The following is a description of a gene set: from publication Chen Y, Wang X (PMID 31504780) studied in species Mus musculus Mouse Gene Set: MIR_6342 Genes predicted to be targets of miRBase v22 microRNA mmu_miR_6342 in miRDB v6.0 with MirTarget v4 prediction scores > 80 (high confidence targets)., and this is the list of marker genes: Chek1, Ythdc1, Colq, Fam151b, Helz, Erlin2, Kpna1, Atf6, Ccnjl, Slit2, Btg2, Rnf144b, G0s2, Cdk5r1, Epha7, Lrig1 (NCBI Gene Id 232256), Ist1, Tbpl1, Dixdc1, Tmem135, Slc4a4, Rab11fip1, Itpr1, Adrb2, Cert1, Mlycd, Casr, Cacul1, Vegfa, Pnpla6, Gbp2b, Syde2, Stradb, Fmn2, Lats1, Wipi2, N4bp1 (NCBI Gene Id 97462), Nuak2, Satb2, Rfx3, Bcl2, Anks1, Adissp, Crebl2, Ywhah, Slc4a7, Plpp1 (phospholipid phosphatase 1), Slc7a2, Sema3a, Dnajc16, Tmem74b, Kctd8, Tgfbr3, Sptbn2, Atxn2, Plcxd2, Arhgap12, Srpra, Cpsf7, Pnoc, Med26, Pip4p2, Ppp6c, Prmt6, Dcp1a, Garem1, Man2a2, Dclk1, Ptpn3, Plxna2, Ubfd1, Grm7, Tmcc1, Kif5c, Bcl2l2, Zfp367, Ccdc85b, Usp42, Kcnj2, Cfap45, Spag7, Zcchc3, Rreb1, Cc2d1b, Tacc1, Mmd, Ncs1, Arih1, Kbtbd2, Myt1l, Peli3, Dll1, Igf2r, Plxna4, Nrn1, Nos1, Abtb2, Sec61a1, Omg, Suco, Ret, Desi1, Smurf1, Selenoi, Zmym2, Krtap11-1, Sall1, Ccnd2, Ippk, Dennd10, Rnf10, Septin2 (septin 2), Eif3a, Cobll1, Capns1, Nectin1, Atp1b4, Atxn7l3, Eya1, Cdk12, Gm5460, Akap7, Ube4b, Nup210, Tuba4a, Mgat4a, Pla2g15, Amotl1, Lhx3, Zfp449, Trabd2b, Hmga1, Ddx3x, Sel1l3, Rasgef1b, Atp2b2, Wbp11, Zswim3, Kif21a, Idh3a, Il10ra, Nav1, Pdxk, Rfc1, Son, Usp25, Cd2ap (CD2-associated protein), Plekhm3, Ahcyl2, Ago4, Penk (preproenkephalin), Bicd1, Slc13a3, Chpt1, Rnf217, Ccdc6, Rbm6, Gpatch8, Capn6, Chd2, Trank1, Pth (NCBI Gene Id 57388), Cdc25a, Prrc2c, Slc25a22, Arfgap2, Arhgdia, Spred1, Usp12, Acvr2a, Plxnc1, Cpeb3, Ankrd13b, Hapstr1, Sema6d, Prdm4, Ano3 (NCBI Gene Id 99077), Rictor, Nrbp1, Etnk1, Cmpk1, Slc39a10, Clock, Fermt2, Ppp2r1b, Akap11, Wnk3, Tenm2, Eda, Sez6l, Lurap1l, Arl2, Akt3, Map2k1, Pwwp2b, Wwp1, Ago1, Klhl2, Shoc2, Zbtb44, Zbtb39, Bmpr1a, Hephl1, Klc4, Kdsr, Onecut2 (one cut domain, family member 2), Angel1, Cdk17, Fgf9, Gm12886, Pam, Rab9b, Kif23, Qki, Plekhh1, Rad23b, Fgf7, Tab3, B4galt1, Zfhx3, Sgk1, Adgrl1, Unc80, Spryd3, Armh4, Mapkap1, Hectd1, Pacsin2, Sall4, Nlrx1, Tbl1xr1, Htr4, Mybl1, Cbfa2t3, Cops7b, Nol4l, Lrrc32, Ppp1r11, Ezh1, Phip, Klc1, Slitrk6, Pik3r1, Actr2, Sik1, Jarid2, Rubcnl, Kif5b, Islr (immunoglobulin superfamily containing leucine-rich repeat), Ash1l (ASH1 like histone lysine methyltransferase), Rere, Zbtb34, Nudt7, Myb, Wnt7a, Abl2, Pappa2, Trp53inp2, Atg14, Traf3, Apln (NCBI Gene Id 77874), Smad7 (SMAD family member 7), Pafah1b1, Ube2q1, Ski, Sox6, Setd3, Ppm1e, Avl9, Socs6 (suppressor of cytokine signaling 6), Caprin1, Sesn1, Luzp1, Usp14, Zfp622, Nudt4, Il7r, Cyp26b1, Ncapg2, Adamts3, Slc20a2, 1700025G04Rik, Sec14l1, Smim13, Cdca4, Mob3b, Cpd, Pou2f1, Cdc37l1, Entpd7, Phf20, Xpo7, Dcaf7, Nup50, Usp15, Cntnap1, Znrf2, Polr3f, Btrc, Kif1b, Scoc, Aff4, Clspn, Fbxo21, Phc3, Tmem178b, Axin2, Pip4p1, Cacna2d1, Phactr2, Wnt3a, Kcnk10, Ccr2, Rarb, Ptprr, Ell, Chac1, Wee1, Dsel, Prkar2a, Lrig2, Higd1a, Gpr63, Cpeb2, Csrnp1, Atp7a, Zfhx4, E2f7, Stxbp3, Mfn2, Seh1l, Ccnt2, Krtap26-1, Kif1c, Fasn (fatty acid synthase), Rasef, Drd1, Tnrc6b, Crebrf, Tlk1, Tll1, Dll4, Fbln5, Fbxw7, Cnot6l, Rab10, Usp31, Pappa, Iars1, E2f3, Lrp6, Med1, Pnp2, Ubn2, Dync1li2, Kl, Phf19, Ccne1, Spsb4, Slc6a11, Reck, Bace1, Cbx6, Aar2, Nfatc3, Ghr, Mex3c, Zfp809, Raf1, Armcx6, Nufip2, Col12a1